The following is a description of a gene set: Human Gene Set: MENON_FETAL_KIDNEY_3_STROMAL_CELLS from publication Menon R, Otto EA, Kokoruda A, Zhou J, Zhang Z, Yoon E, Chen YC, Troyanskaya O, Spence JR, Kretzler M, Cebrián C (PMID 30166318) studied in species Homo sapiens, and this is the list of marker genes: ATP2B1, ALCAM (NCBI Gene Id 214), CALD1, TCF21, GPC3, RAI14, CCDC88A, DST (NCBI Gene Id 80105), ZEB2, MAGED2, NR2F2, PPP1R12A, ITGB1, FN1, POSTN, XIST (X inactive specific transcript), MARCKS, NKTR, SPARC, H19, COL4A2, TNC (NCBI Gene Id 3371), FOS, UACA, RBP1, SEPTIN11, PBX1, SEPTIN7, SELENOW, MEIS2, RPL24P8, MYL6, COL3A1, MYLK, MEG3, AKAP12, PTN, EMCN, CD81, TPM1, C12orf57, COL6A3, FLRT2, TPM2, SOX4, VIM, TOP2B, TMSB4X, KCNQ1OT1 (KCNQ1 opposite strand/antisense transcript 1, NCBI Gene Id 11111), FSTL1, MYH10, PALLD, GNAS, COL5A2, TPM4, CYP1B1, IGFBP5, MDK, SULT1E1, RRBP1, PXDN, COL1A1, SFRP1, COL1A2, NCAM1, RPL28 (ribosomal protein L28), MACF1, VCAN, COL4A1, CHD3, TTC3, COL21A1, SERPINH1, CLDN11, LGALS1, CDH11 (NCBI Gene Id 1009), NR2F1, TUBA1A, CTSC, RPS4XP6, IGF2